Given this list of marker genes Cyp4b1, Ugt1a1, Star, Srd5a2, Ugt2b1, here is a description of the gene set: The chemical reactions and pathways involving biphenyl, a toxic aromatic hydrocarbon used as a heat transfer agent, as a fungistat in packaging citrus fruits and in plant disease control. Biphenyl can be chlorinated with 1-10 chlorine molecules to form polychlorinated biphenyls (PCBs). species: Mus musculus Mouse Gene Set: GOBP_BIPHENYL_METABOLIC_PROCESS